The following is a description of a gene set: Human Gene Set: REACTOME_CARDIOGENESIS studied in species Homo sapiens Cardiogenesis, and this is the list of marker genes: LDB1, HEY1, GATA4, HEY2, CTNNB1, KAT2A, GATA6, SMAD4, KAT5, TBX1, TBXT, SMAD1, MEF2C, SMYD1, NKX2-5, ISL1, EOMES, LEF1, MESP1, TBX20, TBX5, WDR5, FOXO4, SRF, MYOCD, HAND1 (NCBI Gene Id 9421), HAND2